The following is a description of a gene set: A calcium ion entry mechanism in the plasma membrane activated by the depletion of calcium ion from the internal calcium ion store in the endoplasmic reticulum. Human Gene Set: GOBP_STORE_OPERATED_CALCIUM_ENTRY studied in species Homo sapiens, and this is the list of marker genes: CRACR2B, CD84, GRAMD2A, CASQ1, STC2, JPH4, MS4A1, SPG11, SLC8B1, SARAF, CRACR2A, STIMATE, HOMER2, SRL, SPINK1, HOMER1, STIM2, EFHB, STIM1, ORAI1, MIR424, ORAI2 (NCBI Gene Id 84917), ORAI3, HOMER3